The following is a description of a gene set: from publication Konuma T, Nakamura S, Miyagi S, Negishi M, Chiba T, Oguro H, Yuan J, Mochizuki-Kashio M, Ichikawa H, Miyoshi H, Vidal M, Iwama A (PMID 21540074) Each fraction of mouse hematopoietic cells was purified by cell sorting from bone marrow of 8-week-old C57BL/6 mice, and its gene expression was analyzed. Genes up-regulated in comparison of NK cells versus neutrophils. studied in species Homo sapiens Human Gene Set: GSE27786_NKCELL_VS_NEUTROPHIL_UP, and this is the list of marker genes: SNX2, MRM1, SMARCA5, CNDP2, NUP214 (NCBI Gene Id 9680), ETV6, PYCR3, IMP4, DUSP2, SCFD2, CITED4, DCUN1D2, NSUN4, PTK2B, NRARP, SLC15A4, MDC1, DDC, CDC5L, PPP1R7, SCD, DIS3L, ZPR1, GUSB, METTL1, AQR, RNASEH2A, MAN1A2, PI4KA, RHEBL1, PHB1, G3BP1, PPA2, KCNJ8, C10orf88, CKB, REEP5, DDX59, ZFP90, HPS3, RFC5, ZSWIM7, ZC3H13, DNA2, MTHFR, CMYA5, PKIB, MRPL37, MTMR4, PRDM1, C12orf57, ILRUN (inflammation and lipid regulator with UBA-like and NBR1-like domains), STARD10, FEN1, RPUSD4, FCF1 (NCBI Gene Id 51077), ACAD9, CDC16, SAP130, POLR3K, BLTP2, MFSD5, RRP7A, DPH5, TMEM68, MRTFB, PFKL, EXT2, RPUSD2, POMGNT1, GANAB, GNPNAT1, DZANK1, UBXN2A, SSTR4, PGPEP1, FPGT, METTL3, NDUFS7, TTC39C, RPS27L, ZNF841, CD5L, PSMC5, ZNF569, GGA2, BCLAF1, NAB2, ACADVL, TMCC3, SLC35A4, TF, PTPN6 (NCBI Gene Id 5777), MECR, EMC4, DDHD1, ZC2HC1A, EHD3, NDUFA9, BHLHE40, PDGFB, PIK3R1, CAPZA2 (NCBI Gene Id 830), DDI2, MRPL12, NFKBIE, PRKCQ, RAB14, GLTP, FUS, AARSD1, ASXL2, EXOSC1 (exosome component 1), RCBTB2, SAT1, EXT1, GNL2, NSMCE4A, DHX30 (DExH-box helicase 30), SLC44A2, ANO3, H2BC3, PLBD2, PSAP, SESN3, TRIM44, CD3G, GAB2, PSME2 (proteasome activator subunit 2), OAT, IPP, TMEM129, TMEM238, MFSD8 (major facilitator superfamily domain containing 8), HIKESHI, PSMB10, B3GNT5, SPRY2, CTCF, ZNF260, NAAA, GTF2F2, TCF25, SAAL1, GABARAPL1, ARL4D, NDUFAF4, CMKLR1, BUD23, SRSF7, GLRX5 (glutaredoxin 5), MTARC2, PPM1G, STIP1, FBXL17, PPM1K, TRIM27, IL6ST, NSMCE3, NIFK, SLC35B1, DRG2, C2orf88, ITGA2, ADSL, SLFN13, FDX1, UCK1, FBXO32, USP12, CCT6A, ZMIZ2, KMT2E, NIP7, ZNF322, PDLIM1, EMG1, TBCCD1, PLEKHA6, DTWD1, TFB2M, DUSP12, SH3BGRL, ZDHHC21, HES1, DDX24, JAK3, JAGN1, STK10 (NCBI Gene Id 729035), ERCC5, NMT1, CAMK2B, PDXK, ITK, MBNL1, PARP9, PPFIA1 (NCBI Gene Id 8500), PYCARD, TRMT1, RRP36